The following is a description of a gene set: species: Homo sapiens Human Gene Set: GOBP_RESPONSE_TO_SALT_STRESS Any process that results in a change in state or activity of a cell or an organism (in terms of movement, secretion, enzyme production, gene expression, etc.) as a result of a stimulus indicating an increase or decrease in the concentration of salt (particularly but not exclusively sodium and chloride ions) in the environment., and this is the list of marker genes: SLC12A6, CAPN3, SLC25A23, AKR1B1, TRPV4, XRCC6, ABCB1, BAX, LETM1 (leucine zipper and EF-hand containing transmembrane protein 1), BDKRB2, TP53, HSP90AA1, EFHD1, TNF, FXYD2, KMO, MICU1 (NCBI Gene Id 51415), FBP1, AQP1, PAPPA2, ZFP36L1, EPO